The following is a description of a gene set: The functional relationships and properties of different sub-types of dendritic cells (DC) remain largely undefined. We used a global gene profiling approach to determine gene expression patterns among murine splenic CD11c high DC subsets in an effort to better characterise these cells. Genes up-regulated in comparison of ex vivo CD4- CD8- dendritic cells (DC) versus cultured CD4- CD8- DCs. from publication Edwards AD, Chaussabel D, Tomlinson S, Schulz O, Sher A, Reis e Sousa C (PMID 12816982) Human Gene Set: GSE339_EX_VIVO_VS_IN_CULTURE_CD4CD8DN_DC_UP species: Homo sapiens, and this is the list of marker genes: FLI1, PEX2, TYMS (NCBI Gene Id 7298), NEDD4, RHOB, WDR77, PSAP, WDR45B, NSMCE4A, CCL1, FBXW5, ZFP36L2, NFATC3, PAG1, MAD2L1, NIPSNAP2, ECI1, ABCD1, DDHD1 (DDHD domain containing 1, NCBI Gene Id 80821), C1orf174, UGDH, MOGS, PPIF, NLK, HHEX, SUCLG2, SCP2, UCK1, MAP3K3, PTPRE, TIMM8A, NME3, SUSD6 (NCBI Gene Id 9766), SRSF9, ORC6, RELL1, UBQLN1, LENG8, RGS10 (NCBI Gene Id 6001), LTB, ANP32A (acidic nuclear phosphoprotein 32 family member A), MTA2 (NCBI Gene Id 9219), GTF2I, APMAP, VRK1, TRDMT1, TMX1, PPP1R18, ECI2 (NCBI Gene Id 134779), CETN2, H3-5, CDK9, PLCG2 (phospholipase C gamma 2), BOLA2, MED24, PNKP, RBM38, SOS2, TIAL1, INTS7, TMEM59, DNMT1, SPTSSA, SET, VARS1, UVRAG, CCNB2, RNASEH2C, RAMP1, YIPF4, ADGRE5, CIAO2A, SND1 (staphylococcal nuclease and tudor domain containing 1), CBFB (NCBI Gene Id 9163), ABCG2, GOLGA5 (golgin A5), CNOT8, PMPCB, METTL5, PDK1, SNHG6, SRSF7, WAS, NDUFA3, GPN1, XRCC6, PRKCB, KIF2C, RCN1, CLEC4A, SMC2, SRPK3, STX7, XPA, EML5, PTGIS, IER2, PLA2G4A, WDR13, HOXA5 (homeobox A5), UHRF1, LRWD1, PIK3CD, PRKDC, TBC1D22A, ARHGAP39 (NCBI Gene Id 80728), BNIP3L, ZMYND8, RFC5, AP1AR, AURKA, NUSAP1, TSC22D1, EGR2, UIMC1, HPCAL1, VAV2, FGF5, CAT, PDE6D, PPP1R21 (NCBI Gene Id 129285), DGUOK, MMP9, JUN, PIAS3, EHMT2, TIA1, CEBPD, VPS4A, RAP1GDS1, CDKL2, COX4I1, PCLAF, COX14, GTF2A2, CHFR, COQ9, ANAPC13 (anaphase promoting complex subunit 13, NCBI Gene Id 25847), CKS1B, DNAJC3, MIA2, PTPN18, TRAPPC12, RMND1, PYCR3, RASA4, YIPF1, EXOSC5, CASP2, KRTCAP2, TGFBI, ARHGAP9, GM2A, KDM3B, HCK (HCK proto-oncogene, Src family tyrosine kinase), PFKL, TRIM11 (tripartite motif containing 11), DTD1, CCND3, SEPHS2, DPAGT1, CNIH1, ANLN, SIRPA, ACAA1, PTPA, DIPK2A, ZSCAN26, UBA2, CHCHD3, ANK3, RGL1, IL16, KCTD12, MDP1, VKORC1, PSMB9, KNOP1, CTSH, ARHGEF1, CDKN2D, TRAM1, PRADC1, SLC8A1, IKZF1, ELF1, LMO2, TSC22D4, SLC35A1, ARID1A, NRP1, C8orf82, IMPA1, SS18L2, RARS2, PARP8, ACSL5, KAT2B, GNAI1, FBXW2